Given this list of marker genes MKRN3, VPS13B, AUTS2, DPYSL5, KANSL1, HERC2 (NCBI Gene Id 8924), SNRPN, GNB1, NPAP1 (NCBI Gene Id 23742), PWAR1, PWRN1, SNORD116-1, SMS, UBE3B, KMT2B, NDN, MAGEL2, SNORD115-1, here is a description of the gene set: Narrow palm Human Gene Set: HP_NARROW_PALM species: Homo sapiens For children from birth to 4 years of age, the palm width is more than 2 SD below the mean; for children from 4 to 16 years of age the palm width is below the 5th centile; or, the width of the palm appears disproportionately narrow for its length.